Given this list of marker genes Ngfr, Sqstm1, Ikbkb, Rps27a, Ngf, Ubb, Nfkbia, Irak1, Rela, Myd88, Nfkb1, here is a description of the gene set: Reactome Pathway: p75NTR signals via NF-kB This event has been computationally inferred from an event that has been demonstrated in another species.<p>The inference is based on the homology mapping from PANTHER. Briefly, reactions for which all involved PhysicalEntities (in input, output and catalyst) have a mapped orthologue/paralogue (for complexes at least 75% of components must have a mapping) are inferred to the other species. part of: p75 NTR receptor-mediated signalling species: Mus musculus electronically inferred by orthology from the curated human pathway